Given this list of marker genes FFAR2, PLEKHF2, PTGS2, DUSP2, SLAMF7, MIR9-1HG, LDLRAD4, EIF1B, BIRC3, KDM7A-DT, IL2RA, PLD1, GADD45A, DENND4A, RND1, B3GNT2, ADM, PLEK, PIM3, PSMA6, PTP4A1, NFKBIZ, CD83, CXCL3, NFKBIA, RAB33A, IER3, STAT5A, ELOVL7, POLR1F, TNIP3, CFLAR, SFMBT2, REL, INHBA (inhibin subunit beta A), ATP2B1, STARD4, RASGEF1B, NAF1, ICAM1, IL12B (interleukin 12B), IL6ST-DT, ARL5B, TNF, MMP7, PDSS1, DNAJB4, IL6-AS1 (IL6 antisense RNA 1), TP53BP2 (tumor protein p53 binding protein 2), NUP58, CAMK1G, TPD52, CCL4, GCH1, PIK3AP1, DRAM1 (DNA damage regulated autophagy modulator 1), EGR1, HNRNPC, RAPGEF2, ID2, SGMS1, NOCT, TAF9, NEDD4L, ADORA2A-AS1 (ADORA2A antisense RNA 1), CASP5, ACOD1 (NCBI Gene Id 730803), G0S2, TJP2, NFKB1, IL18, MIR155HG, SFR1, OTUD4, LRRC8C, MUCL1, SOD2, ETS2, MIR3945HG, MAP3K4, SIAH2, SELENOK, SGPP2, DDX5, EDN1, CCL23, IL1A, PNPLA1, IL10, JUN, DNAAF1, IL6, IL15RA, UBE2J1, IL23A, CXCL2, IL1B, GPR84, DCUN1D3, PLK3 (polo like kinase 3), NFKBID, DENND5A, RHOH, TMEM88, TNFAIP6, PIM2, ICAM4, MGAM, RIPK2, HECW2, DLGAP1-AS1, CT75, PLAUR, KANK1, RYBP, PPP1R15A, SAV1, TIFA, DLGAP1-AS2, F8, PMAIP1, MIR3142HG, CCR7, FOSL1, NFATC1, TARP, BCL2A1, ZNF697, KDM6B, DYRK3, DUSP1, AREG, ATP2B1-AS1, AQP9, GADD45B, ADTRP, SLC7A5, PELI1, BTG2, CHAC1, ABL2, ADRB2, CYB5D1, RBM17, NIPAL4, TNFAIP3, MAFF, TNFAIP2, LINC01465, FJX1, CDK1, OTUD1, LAMP3, CCL20, FNIP2, ZNF674-AS1, YRDC, CCL18, DUSP5 (NCBI Gene Id 1847), MAP3K8, SNX9, PHLDA2, LAMB3, CSRNP1, ACSL1, CXCL8, CCNB1, C11orf96, TXN, E2F7, CXCL1, XBP1, UAP1, CFLAR-AS1, ZC3H12A, LINC00299, LINC01093, CCRL2, RPGR, DDIT4 (NCBI Gene Id 54541), SERPINB8, PPP1R15B, MSANTD3, PTX3, SOCS3, CD274, TLCD3A, IL36G, NLRP3, STARD8, GEM, TDH, NEMP1, MFSD2A, USP12 (ubiquitin specific peptidase 12), TMPO-AS1, STK26, here is a description of the gene set: Genes up-regulated in comparison of monocytes treated with 1 ng/ml LPS (TLR4 agonist) versus untreated monocytes. TREM-1 is an orphan immunoreceptor expressed on monocytes, macrophages, and neutrophils. TREM-1 associates with and signals via the adapter protein DAP12/TYROBP, which contains an immunoreceptor tyrosine-based activation motif (ITAM). TREM-1 activation by receptor cross-linking is pro-inflammatory, and can amplify cellular responses to Toll-like receptor (TLR) ligands such as bacterial lipopolysaccharide (LPS). To investigate the cellular consequences of TREM-1 activation, we have characterized global gene expression changes in human monocytes in response to TREM-1 cross-linking in comparison to and combined with LPS. Both TREM-1 activation and LPS up-regulate chemokines, cytokines, matrix metalloproteases, and PTGS/COX2, consistent with a core inflammatory response. However, other immunomodulatory factors are selectively induced, including SPP1 and CSF1 (i.e., M-CSF) by TREM-1 activation and IL-23 and CSF3 (i.e., G-CSF) by LPS. Additionally, cross-talk between TREM-1 activation and LPS occurs on multiple levels. While synergy in GM-CSF protein production is reflected in commensurate mRNA abundance, comparable synergy in IL-1b protein production is not. TREM-1 activation also attenuates the induction of some LPS target genes, including those that encode IL-12 cytokine family subunits. Whereas positive TREM-1 outputs are abolished by the PI3K inhibitor wortmannin, this attenuation is largely PI3K-independent. These experiments provide a detailed analysis of the cellular consequences of TREM-1 activation, and highlight some of the complexity in signal integration between ITAM- and TLR-mediated signaling. from publication Dower K, Ellis DK, Saraf K, Jelinsky SA, Lin LL (PMID 18292579) species: Homo sapiens Human Gene Set: GSE9988_LPS_VS_VEHICLE_TREATED_MONOCYTE_UP